Given this list of marker genes ALK, UGT1A1, WFS1, AHDC1, TNFAIP3, MRPL12, EIF4H, GTF2E2, NEMF, MOCS1, CRH, ATXN1, SLC25A22, ASAH1, BRAT1, RNASET2, TBCD, KCNC1, AASS, SLC30A9, PRPH, FGF13, SC5D, PHOX2B, KCNT1, ATP7A, MAN1B1, SELENOI, CLTC, COL25A1, KATNIP, AP5Z1, SETX, PRNP, POMT2, RPL10, VWA3B, TRIO, TPI1, CAMK2A, SLC52A2, CP, PPP2R2B, MSTO1, OFD1, ERCC2, GPR88, DHDDS, ATXN10, TOPORS, FZR1, MT-CO2, ZFYVE26, SLC25A11, PON2, CACNA1H, GAMT, ADAMTS13, MPZ, SLC12A6, GTF2H5, MINPP1, MECR, KCNK9, GM2A, DNMT1, PRICKLE1, ATXN3 (ataxin 3), NIPA1, ABCA7, GLT8D1, TSFM, PRX, RARS1, DPM1, PDHA1, OSTM1, PEX6, NDUFA9, PIK3R5, AARS1, HSPD1 (heat shock protein family D (Hsp60) member 1), ABHD16A (NCBI Gene Id 7920), ABCB4, PITRM1, LRSAM1, CACNA2D2, RAB18, KIAA0753, DDC, GLRA1, MMAA, PIBF1, PLA2G6, TXN2, SLC25A19, CACNA1A, RAB3GAP2, NPTX1 (neuronal pentraxin 1), RNF113A, PIGV, TCTN2, ITPA, SLC25A42 (NCBI Gene Id 57831), NDP (norrin cystine knot growth factor NDP), CEP120, TMEM106B (NCBI Gene Id 54664, transmembrane protein 106B), UBTF, SLC6A19, TOR1A, KDM1A, NDUFS8, YWHAG, SEMA6B, CHCHD2, BAP1, GNB1, PIGT (NCBI Gene Id 94004), GALT, LMNB2, RNASEH1, KCNC2, GTF2I, FBXO7, NUTM2B-AS1, SLC2A1, NHLRC1, SLC17A5, GCH1, HNRNPA2B1, SLC2A3, STXBP1, NFASC, RILPL1, ADRA2B, PRDX3, NDUFAF5, TLR7, TNRC6A, SPEN, ELN, HINT1, TGM6, TRAPPC12, IRF2BPL, HMGCL, VLDLR, PRPS1, CPLANE1, MT-TV, MT-ND2, MFN2, CDK19, CNPY3, CDC42BPB, CD40LG, SLC1A3, ZNF365, HCFC1, ATG7, GLRX5, PLPBP, SLC5A7, TPK1, ATP5MK, ATP1A3, SLC16A2, PPP3CA, FGF12, MPV17, SH3TC2, GABRB3, POMGNT1 (protein O-linked mannose N-acetylglucosaminyltransferase 1 (beta 1,2-)), PAH, VPS13D, SORL1, LRP12, GABBR2, PNKP, ARX, STX16, PLP1, RAPGEF2, PARK7, EEF2, PITX3, CCDC141 (coiled-coil domain containing 141), SYNE1, PET100, NTRK2, ATP8B1 (NCBI Gene Id 5205), MYBPC1, IRAK1, TMEM216, MT-TL1, ABCB11, VPS37A, ZNF142, ST3GAL5, FRMPD4, GJA5, TIMM8A, VRK1, DARS2, DNASE1, SDHC, CLCN4, CASR, GJC2, SQSTM1, SCN1A, MED23 (NCBI Gene Id 9439), ATAD1, CLN3, HYCC1, HPRT1, CYP7B1 (cytochrome P450 family 7 subfamily B member 1), STX1A, AKT1, PEX2, KCND3 (NCBI Gene Id 3752), LONP1, COA7, OPA3, CYFIP2, CIC, RRM2B, PNPLA6, TTR, PDGFRB, MT-ND1, PTEN, RNASEH2B, YY1, GLE1, TOGARAM1, KCNC3, CHMP1A, APOE, CTLA4, ELOVL5, WWOX, MYL2, NSD1, NARS1, SLC25A4, THOC2, CYP27A1, C19orf12, EXTL3, GCK, FKBP6, REEP2 (receptor accessory protein 2), AP3B2, FA2H, UBA5, HMBS, POLR3A, ZFX, PARS2, DNAJC13, FIG4, SCYL1, MT-TT (mitochondrially encoded tRNA-Thr (ACN)), VAC14 (VAC14 component of PIKFYVE complex), CUL4B, IREB2, TMEM231, NEFH, TECR, ADGRV1, PDGFB, LEMD3, AP2M1 (NCBI Gene Id 1173), MPLKIP, DAO, KCTD17, KCNMA1, ELOVL1, TSPOAP1, NDUFAF3, KNSTRN, FOXRED1, FXN, SPR, GOSR2, SAMD12, QRICH1, PFN1, MECP2, TSEN54, CR2, FRMD5, LEMD2, CTC1, SYT2, ANO10 (anoctamin 10), ATXN8OS, MT-TH, MT-ND4, SPG11, DYSF, NUP214, B9D2, NF2, TSPYL1, CAMTA1, DAB1, EPM2A, PRKCG, CCDC88A, POU3F4, CHRNA4, KCNA2, PDE10A, MOCS2, DCC, GABRD, NECAP1, SCN3A, FARS2, MAG, ERBB4, CPLX1 (NCBI Gene Id 10815), TNIP1, RAB39B, ACBD5, KCNB1, MKS1, PIGL (phosphatidylinositol glycan anchor biosynthesis class L), PSAT1, SPG21, CHD2, SPAST, CLCN2, SLC25A46, SDHB, NDUFA1, IRF5, NT5C2, SBF2, EXOSC8, TIMM50, ADAR, SPRY4 (sprouty RTK signaling antagonist 4), LIMK1, FOXG1, ACTL6B, TERT, SLC38A3, GJA8, SEPSECS, GLRB, ABHD12, SATB1, HYLS1, ERCC3, RFC1, MT-TP, CACNB4, SLC6A3, CYB5R3, SH2B1, ADSL, PGK1, HLA-DRB1, FGF8, FTL, CTSF, GFM2, RNASEH2A, HNRNPU, EBF3, ITPR1, GBA1, EMILIN1, ADPRS, PROKR2, DPYSL5, ELP2, SFXN4, YRDC, NAXE, CSTB, CA8, GABRA3, HNF4A, CAV1, POU4F1, SLC1A2, COQ7, U2AF2, KARS1, NFU1, PSAP, GNAS, TCEAL1 (transcription elongation factor A like 1), RFC2, CDH23, UROC1, NR1H4, CLN5, APP, CLTRN, MTOR, THG1L, GLB1, NDUFA13, TNNT1, PNPLA2, FCGR2B, PEX16, JAZF1, ACP5, SLC33A1, KCNQ3, USP8, NONO, DUSP6, HEXB, CHMP2B (NCBI Gene Id 7877), SUCLA2, BAZ1B, NR4A2, CBY1, NOL3, STUB1, MMUT, ERCC4, PIGO (phosphatidylinositol glycan anchor biosynthesis class O), ERCC5 (NCBI Gene Id 2073), PGAP1, HACE1, ARL13B, WARS2, ABCD1, DRD2, GABRA2, BICD2, GABRB2, RNASEH2C, SYT1, PNPT1, NDUFA4, LIN28B, PCDH19, CACNA1B, IL17RD, IFT74, UBAP2L, SCP2, NEXMIF, MTFMT, CNBP, ANOS1, COQ2, ERGIC1, TMEM237, LRRK2, MYO5A, MT-TW, PON1, MT-TQ (mitochondrially encoded tRNA-Gln (CAA/G)), KPNA3, CLIP2, LIG3, MMACHC, MTPAP, GRIK2, BSCL2 (BSCL2 lipid droplet biogenesis associated, seipin), MAOA, GIGYF2, SCN4A, YEATS2, ADA2, ATP6V1A, GTF2IRD1, RTN2, SLC39A14, SUOX, TRAPPC6B, SLC25A15, CLPB, DENND5A, ZNHIT3, MT-CO3, PTCD3, TIMMDC1, BEAN1, XPNPEP3, AGTPBP1, POLR1C, TTPA, ATP2B3, UBQLN2, DMXL2, ASNS, MT-ND6, TMEM222, PDK3, CD28, TRAK1, DNAJC19, CRYAB, MICU1, MUSK, GMPPB, TRIM8, PRKN, PODXL, GTF2IRD2, SPOP, SLC44A1, RHOBTB2, EXOSC3, RNU12, VAMP1, MME, CHRNA2, NAGA, GRIN2A, HCRT, TMEM63A, PSEN2, VPS13A, PANK2, TRMT5, TCIRG1, UCHL1, POLR3B, GRM1, GABRG2, TCTN3, TTI1, PGM3, POMK, DNAJC30, MT-CYB, GABRA5 (gamma-aminobutyric acid type A receptor subunit alpha5), HS6ST1, SNX10, PON3, NUS1, AMACR, CAPRIN1, APC2, XPR1, LGI3, MEGF10, GFAP, CEP41, NDRG1, SYNJ1, PC, CACNA1S, CDKL5, CUX2, IVD, MACF1, NUP54, NF1, CEP104, CLN8, HMGA2, AFF3, NAXD, VHL, MRM2, P2RY11, CCDC88C, ABCB6, ETS1, ATP6V0A1, BUD23, VPS53, NOTCH2NLC, PNPO, CRAT, TMEM218, MAPK10, MYH14, TEFM, ERCC8, LIAS, SV2A, JPH3, SLC1A4, GRIN1, NDE1, SMARCB1, HSD17B4, NEUROD2, AHI1, NCF1, CSPP1, ATN1 (NCBI Gene Id 1822), DNM1L, KCNJ10, SPTBN4, ATP13A2 (NCBI Gene Id 63919), RNF216, HPCA, SMG9, UNC13A, TBP, GPR101, CAMLG, NDUFS2, BANK1, RNU7-1, VPS37D, SLC4A10, UGDH, ANO3, VPS13C, CEP126, PTPN22, TANGO2, PMM2, VPS4A, PHACTR1, SUCLG1 (succinate-CoA ligase GDP/ADP-forming subunit alpha), SDHA, DNM1 (dynamin 1), KCNJ18, TUBB4A, GPHN, CELF2, GNA11, FTH1, SMPD1, PMP2, APTX, NEK1, HNRNPA1, CILK1, MRE11, NOP56, TNPO2, XPA, KCTD7, NGF, TNFSF11, REPS1, FXR1, PGAP2, EIF2AK2, OXR1, ATXN2, LYST, LMO1, DCAF17, CARS2, ARL3, DOCK7, PDE6D, TNR, GGT1, RPGRIP1L (RPGRIP1 like), HIBCH (3-hydroxyisobutyryl-CoA hydrolase), TREM2, SCN9A, SMN1, PNP, RORB, SCARB2, NTNG1, NKX6-2, MT-TS2, CWF19L1, NEFL, TRPM3, MATR3, FMR1, BLK, PRUNE1, IFRD1, TSEN2, SLC25A13, ACAT2, LNPK, MT-TF, PCBD1, OPA1, SLC30A10, COL6A3, POLR3K, AUH, DPAGT1, FH, ITM2B, TPR, COX20, KIF1C, DRD3 (NCBI Gene Id 2111), KCNA1, DHX30, MRAP, MDH2, FLRT3, SLC6A9, TARDBP, DLAT, TMEM270, SLC39A4 (NCBI Gene Id 55630), TOE1, ASL, WDR45, SLC46A1, PRDX1, FEZF1, FGFR1 (fibroblast growth factor receptor 1), DHFR, GRIA2, NGLY1, PACS2, PMP22, KCNQ2, DTYMK, DDOST, MRPS34, NKX2-1, RBM10, HTRA2, PIGA, PDE2A, HESX1 (HESX homeobox 1), VAMP2, PHGDH, SCN8A, LAMA1, PIGY, FBXL4, CLN6 (CLN6 transmembrane ER protein), NDNF, PSMC1, OCA2, CRELD1, PIK3CD, RYR1, GSS, DEAF1 (DEAF1 transcription factor), GUF1, SPTBN2, STX1B (syntaxin 1B), UQCRQ, EPAS1 (endothelial PAS domain protein 1), CTH, POLR1A (NCBI Gene Id 90784), ATCAY, TFG, KIF1A, REEP1, MT-ND3, ADCY5, TMEM127, SLC6A8, MTRFR, PXK, DNMT3A, KMT2B, SGCE (NCBI Gene Id 8910), SYNGAP1, ADGRG1, GPAA1, LRPPRC, ABCC8, CHD7, DMD, ACBD6, CACNA1G, ACO2, MYCN, RLIM, AIFM1, CERS1, LMAN2L, CNKSR2, ITGAM, TENM4, VAPB, SZT2, AP1S2, RUSC2, PTS, PIGP, EIF4G1, TARS1, TMEM70, CTDP1, TSEN34, PDCD1, SPART, SLC20A2, RET (ret proto-oncogene), GRIN2B, KIF1B, PURA, TMEM240, GRIA4, RNU4-2, SIGMAR1, UBE3A, DLST, PPT1, TBL2, COX4I1, SMC1A, WDR81, HSD17B10, COQ8A (NCBI Gene Id 56997), CCNF, ARMC9, UBE2L3, PDE8B, ABCB7, CC2D2A, NDUFS4, SCO2, EPRS1 (NCBI Gene Id 2058), KIF5A, SLC6A1, PHIP, GRIA3 (glutamate ionotropic receptor AMPA type subunit 3), GCDH, NDUFV1, PIGN, FGF17, VPS41, PTPA, GBA2, MED17, PLCB1, CLCN7, SIK1, SMO, SMN2, TBK1, HCN1, SLC6A17, GLDC, TRAPPC11, MICOS13, NFE2L2, FLVCR1, POU3F3, SLC52A3, TNFRSF1B, MT-CO1, CAPN1, RMND1, YME1L1, INPP5E, AR, SLC13A5, TMEM67, PTRHD1, NPHP1 (nephrocystin 1), TACR3, DNAJC6, TK2, SLC19A3, AIP, MOG, POMT1, GABRA1, MT-ND4L, GJB1, TNFSF4, PEX10, ERLIN1, PRRT2, MORC2, ATP7B, CIZ1, LMNB1, COQ6, MT-TI, CCT5, TSEN15, CFAP410, TAT, ALDH18A1, SDHD, NAA60, NEU1 (neuraminidase 1), OPHN1, MT-ATP6, JRK, HIKESHI, CRLS1, MYORG, SNCAIP, PSEN1, FKRP, CNTN2, LSM11, PYCR1, MARCHF6, CARS1, DEPDC5, SNRPN (NCBI Gene Id 6638), PIGQ, TOMM40, PNKD, SLC25A12, TMCO1, TPP1, ATP1A2, CYB5A, SERPINI1, POLG, RAB7A, CTNND2, IL10, SCN1B, SEMA3A, PROK2, LZTR1, MAPT, ANXA11, NHLRC2, SLC9A1, SMARCE1 (SWI/SNF related, matrix associated, actin dependent regulator of chromatin, subfamily e, member 1), NTNG2, SLC18A2, STAT4, CACNA1E, BOLA3, MAX, ERCC6, SHQ1, TWNK, ALS2, GRN (granulin precursor), SLC6A5, GALC, MARS1, SLC7A6OS, FBXO28, CACNA1D, UQCRC1, MT-ND5, MEN1, NUP62, EFHC1, SAMD9L, ELOVL4, PDYN, IRF4, XK, UBA1, TTC19, ADH1C, ZFR, COG8, PMPCA, SLC25A10, KCNN2 (NCBI Gene Id 3781, potassium calcium-activated channel subfamily N member 2), PI4KA, CHKA, UFC1, KIAA0319L, JAG1, GLYCTK, ARSA, IMPDH2, ATL1, PIK3CA, SOX10, ATP6AP2, GCSH, SPTBN1, MED11, EXOSC9, C4B, GLA, ERLIN2, GNAO1, PI4K2A (phosphatidylinositol 4-kinase type 2 alpha), CHRNB2, TSHR, PRKAR1B, THAP1, VWA1, TCTN1, CASK, GTPBP2, MT-ATP8, GOLGA2, TAF1, STARD7, METTL27, FBXO38, DALRD3, WDR11, SCN2A, PRKRA, PGAP3, SNORD118, UBAP1, TMEM151A, AMPD2, IGHG1, HSPB1, ATP6V1B2, EGR2, DNAJC5, TRAF7, TREX1, FGF14, AFG3L2, FAM149B1, PUS7, GRM7, SPTLC1, FRRS1L, SMS, PINK1, AKT3, SPTAN1, SDHAF2, ST3GAL3, KIAA0586, PPARGC1A, ENSG00000288330, EEF1A2, TH, UBE3C, POLG2, PRORP, GPT2, VCP, CACNA2D1, C4A, ATM, CACNA1C, ATP2A1, CHCHD10, MT-TK, SOD1 (superoxide dismutase 1), SACS, FCGR3B, STAMBP, SUFU, TAF15, CEP85L, KLC2, KIF7, RFT1, GRIN2D, TBC1D24, CTSH, OPTN, AARS2, SPP1 (NCBI Gene Id 6696), SNCA, OCRL, SLC32A1, CABP4, ANG, COQ5, NADK2, B9D1, SCYL2, VPS35, DCTN1, PPP1R15B, RORA, QDPR, IFIH1, GON7, ATXN7, ATP11A, PIGW, TYROBP, SLC25A21, PTH, HTT, PRDM8, COQ4 (coenzyme Q4), SAMHD1, KCNK4, HLA-DQB1, FUS, WASHC5, here is a description of the gene set: studied in species Homo sapiens Human Gene Set: HP_INVOLUNTARY_MOVEMENTS Involuntary movements Involuntary contractions of muscle leading to involuntary movements of extremities, neck, trunk, or face.